The following is a description of a gene set: The directed killing of a target cell by a leukocyte. species: Mus musculus Mouse Gene Set: GOBP_LEUKOCYTE_MEDIATED_CYTOTOXICITY, and this is the list of marker genes: Ptprc, Il7r, Il18rap, Raet1e, Kctd9, Pomc, Klri1, Ncf1 (neutrophil cytosolic factor 1), Klrd1, Nectin2, Ebag9 (estrogen receptor-binding fragment-associated gene 9), Spi1, Klri2, H2-M10.5, Tap1, Stat5a, H2-Q6, Mill1 (NCBI Gene Id 266815), Klrc2, Gfer, Serpinb9g, Arg1, Ncr3-ps, H2-M10.2, Lyst (lysosomal trafficking regulator), B2m, Coro1a (NCBI Gene Id 16902), H2-K1, Klrc3, Ap1g1, H2-T13, Tusc2, Pik3r6, Sh2d1a (NCBI Gene Id 279676), Gzmm, H2-Ea, Fcgr4, Il21, Klrc1, Hspa8, Xcl1, Prdx1, Stx11, H60b, Tap2, Klrb1, Stat5b, Lgals9, H2-M10.1, Cadm1, H2-M9, Grb2, Kif5b, H2-M3 (NCBI Gene Id 14991, histocompatibility 2, M region locus 3), Pik3cb, Cd160, Cxcl5, Tyrobp (NCBI Gene Id 22177), Nlrp6, Ulbp1, Rasgrp1, Elane, Serpinb9e, Azgp1, Klrb1f, Pvr, Ccl2, 2410137M14Rik, Clec2d, Crtam, Arl8b, Gfus, Gzmn (NCBI Gene Id 245839), Muc4, Slc22a13, Ighe, Nkg7, Clec12b, H2-M1, Ctsh, Rab27a, Ripk3, Itgam, Raet1d, Cyrib, Serpinb9f, H2-T5, Ulbp3, Cd2, Trem1, Cebpg, Fadd, Emp2, Unc13d, Cx3cr1, Havcr2, Ighg1 (immunoglobulin heavy constant gamma 1 (G1m marker)), Trem3, Cd226, Sh2d1b2, P2rx7, Igf2, Gimap3, F2, Stxbp2, Vav1, Nectin4, H2-M11, Slamf6, Fcgr1, Cd1d1, H2-T15, Lamp1, Gzmb, Klrk1, H2-M5, H2-Q2, Tgfb1, Hprt1, Cd1d2, H2-M10.3, Il12b, Il18, Serpinb9b, Sh2d1b1, Scnn1b, H2-M10.6, Crk, Myd88, H2-M2, Fcgr3, H2-Q7, Nckap1l, Arrb2, Lag3, Pnp (purine-nucleoside phosphorylase), Prf1, Ceacam1 (CEA cell adhesion molecule 1), Inpp5d, Il12a, Ptpn6, Stap1, Plekhm2, H2-T22, Serpinb9h, H2-T24 (NCBI Gene Id 15042), Serpinb9c, Fcgr2b, Klrb1b, H2-Q4, Pik3r1, Il23a, Klre1, Pcyox1l, Stx7, Serpinb9, Rnf19b, H2-T23, Dao, Mr1, Cxcl1, Hcst, Klrb1a, H2-Q10, Serpinb9d, Lep (NCBI Gene Id 16846), Dnase1, Klrb1c, Ager, Gzmc, H60c, F2rl1, H2-M10.4, Dnase1l3, Ctsc, Ctsg, H2-D1, Gimap5, Ppp3cb, H2-T3, H2-Q1 (histocompatibility 2, Q region locus 1)